Given this list of marker genes ISG20, DNASE1L3, POLDIP3, DYNLL1 (dynein light chain LC8-type 1), N4BP2L1, CCL22, MAPKAPK5, PRLR, MUC2, DCAF11, CDH1, CEACAM1, ENPP2, NET1, CD83, RRBP1, PFKFB1, LMNB1, CCL4, MISP, LPIN1, GADD45B, UBN1 (NCBI Gene Id 50641), CCL5, XPO6, CD84, PTPN7, CYP3A5, RABEPK, VPS52, IRF5, PLPP3, IRF9, FABP4, TNNC2, CTSC (cathepsin C), EOLA2-DT, GNAO1, GLA, SP110, CLCNKA, CFHR3, ZG16, CH25H, TOMM34, GBP1, IFIT3, LIPA, BSN, IL1RN, OAS2, MYOC, CD47, UBTF, RUBCN, HSD3B2, CCNH, PUM3, HLA-DQB1, UBA7, HSP90AB1, NRP2, CDV3, MRC2, PES1, PMM1, AGRN, SULT2B1, RBBP8, PTGER4, PTH, TRAFD1, PSMD1, TXN, GADD45A, TNFRSF4, SEC61B, NGFR, EIF4A1, ZDHHC18, TRAF5, STAT2, DDAH1, CERS6, HLA-DMA, MAP3K4, CCR7, TP53BP2, RBPMS, KRT2, TAOK2, APOH, PAX4, CD1E, PIM2, TNFAIP6, DEFA5, CCL8, IL4, ARHGAP25, MRC1, SOD1, LYZL6, HSD11B1, PLK1, GPR35, FN1, CXCL10, IRF1, TRAF1, SYN3, DNAH7, IFITM1, MAGEB2, CUL1, ETV6, MSC, LTK, CCL18, MX1 (NCBI Gene Id 4599), ALDH1A2, ARAP2, ARID1A, EPB41, NUP188, TXNRD1, S100A11, IL7R, MYH6, RIPK1, CLIC2, CCNF, CENPA, SLC7A8, HOMER2, NEMP1, SSB, KDM4C, CCL2, COL7A1, HIC2, GREB1, POLR3C, PCDHB11, MEF2C, PXDC1, KIF3C, ATP2A2, DYNLT1, IFIT1, FMO4, IL3RA, ANPEP, SASH3 (SAM and SH3 domain containing 3), EZH2, CDK2AP1, PLIN1, ALPI, DIAPH1 (NCBI Gene Id 1729), PPBPP2, DYNC1H1, IL6, FABP5, MRPS31, GJB1, ADRA2C, IFI35, CXCL11 (NCBI Gene Id 6373), DUSP5, SMOX, OSTF1, HMGN3, RBM3 (NCBI Gene Id 5935), NFKB1, TUBB, NDST1, LYST, TRIB1 (tribbles pseudokinase 1), KRTAP26-1, BBS9, AKR1B1, CD3D, TRIM14, JUP, BRD2, CST7, OASL, PSMA5, KCNV2, HEG1, HLA-DRA, PSME2 (NCBI Gene Id 5721), LYRM9, ATF5, PALLD, TIMP3, here is a description of the gene set: Genes up-regulated in comparison of dendritic cells (DC) exposed to M. tuberculosis versus macrophages exposed to L. major. Monocyte-derived dendritic cells (DC) and macrophages (MΦ) generated in vitro from the same individual blood donors were exposed to five different pathogens, and gene expression profiles were assessed by microarray analysis. Responses to Mycobacterium tuberculosis and to phylogenetically distinct protozoan (Leishmania major, L. donovani, Toxoplasma gondii) and helminth (Brugia malayi) parasites were examined, each of which produces chronic infections in humans yet vary considerably in the nature of the immune responses they trigger. species: Homo sapiens Human Gene Set: GSE360_DC_VS_MAC_M_TUBERCULOSIS_UP from publication Chaussabel D, Semnani RT, McDowell MA, Sacks D, Sher A, Nutman TB (PMID 12663451)